Given this list of marker genes IL3RA, GPC3, ABCD1, PDHA1, NXT2, MAGEA6, UBE2A, HDGF, EIF1AX, FAM3A, SDHD, MEG3, MTM1, IDH3G, UBA1, IGF2, IRAK1, here is a description of the gene set: Methyl-cytosine-phosphate-guanine (CpG)-binding domain (MBD) proteins are bound to hypermethylated promoter CpG islands of tumor suppressor genes in human cancer cells, although a direct causal relationship at the genome-wide level between MBD presence and gene silencing remains to be demonstrated. To this end, we have inhibited the expression of MBD proteins in HeLa cells by short hairpin RNAs; and studied the functional consequences of MBD depletion using microarray-based expression analysis in conjunction with extensive bisulfite genomic sequencing and chromatin immunoprecipitation. The removal of MBDs results in a release of gene silencing associated with a loss of MBD occupancy in 5'-CpG islands without any change in the DNA methylation pattern. Our results unveil new targets for epigenetic inactivation mediated by MBDs in transformed cells, such as the cell adhesion protein gamma-parvin and the fibroblast growth factor 19, where we also demonstrate their bona fide tumor suppressor features. Our data support a fundamental role for MBD proteins in the direct maintenance of transcriptional repression of tumor suppressors and identify new candidate genes for epigenetic disruption in cancer cells. X chromosome and imprinted genes up-regulated in HeLa cells (cervical cancer) after knockdown of the MBD (methyl-CpG binding domain) proteins by RNAi. from publication Lopez-Serra L, Ballestar E, Ropero S, Setien F, Billard LM, Fraga MF, Lopez-Nieva P, Alaminos M, Guerrero D, Dante R, Esteller M (PMID 18223687) Human Gene Set: LOPEZ_MBD_TARGETS_IMPRINTED_AND_X_LINKED studied in species Homo sapiens